The following is a description of a gene set: studied in species Mus musculus Genes predicted to be targets of miRBase v22 microRNA mmu_miR_214_5p in miRDB v6.0 with MirTarget v4 prediction scores > 80 (high confidence targets). Mouse Gene Set: MIR_214_5P from publication Chen Y, Wang X (PMID 31504780), and this is the list of marker genes: Zfp24, Tm4sf20, Tfdp1 (transcription factor Dp 1), Anxa9, Lig3, Col4a6, Lrrtm4, Fyco1, Tub, Nell2, Acvrl1, Naip2, Pkia, Arhgap28, Pomgnt1 (NCBI Gene Id 76888), Nckap1l, Lypd1, Ube2k, Zfp516, Mybl1, Nadk2, Wdr41, Rcbtb1, Samd4b (NCBI Gene Id 233033), Kansl2, Nos1, Meltf, Stk35, Crebl2, Cplx2 (complexin 2), Zfp704, Chst10, L1cam, Or51l4, Lrrc63, Naga, Tmprss11f, Syn3, Gnao1, Armh3, Usp45, Rbfox2, Nxf1, Ulk3, Khdc1a, Kdm2a, Ing5, Tasl, Zfp687, Wdr89, Zcchc10, Nr2c1, Lipt2, Foxj2, Aldh9a1, Wdr77, Brd1, Trib1, Tmem252, Bdp1